Given this list of marker genes PKD1L1, DGCR2, WDR26, DGCR8, IFT56, DGCR6, ACVR2B, PLXND1, TBX1, DNAH1, CLXN, CHD7, TBCK, CIROP, FLT4, CFAP53 (cilia and flagella associated protein 53), ZMYM3, GDF1, CRELD1, MMP21, TMEM260, DNAH9, STRA6, SF3B2, ESS2 (ess-2 splicing factor homolog), WT1, NKX2-6, here is a description of the gene set: studied in species Homo sapiens Aorta descends on right instead of on the left. Human Gene Set: HP_RIGHT_AORTIC_ARCH Right aortic arch